The following is a description of a gene set: studied in species Homo sapiens Tryptophan catabolism Human Gene Set: REACTOME_TRYPTOPHAN_CATABOLISM, and this is the list of marker genes: KYAT3, ACMSD, AADAT, KYAT1, SLC7A5, IDO1 (NCBI Gene Id 3620, indoleamine 2,3-dioxygenase 1), AFMID, TDO2, SLC36A4, HAAO, SLC3A2, IDO2, KMO, KYNU